Given this list of marker genes ZNF302, C7orf25, ERG28, ZNF814, ZNF732, N4BP3, HNF4G, ZNF268, ZNF384, CTAGE1, KLC4 (NCBI Gene Id 89953), XKR6, ZNF584, MSTO1, ZNF559-ZNF177, ZNF124, BRK1, LIMD2, UBTD2, LARP1B, EBAG9, RPS3, SPEN, AGO1, ZNF559, TMEM178B, GCC1, ZNF440, ZFYVE9, UGT8, LHX1, KCNIP1, PDXK, HDDC3, IKZF2, ZNF544, HOXD13, CAP1, GALNT2, KLHL32, THEM4, BORCS6, UFM1, UBQLN4, SLC37A3, ZFP90, SEMA3A, ZNF781, CR1, L3MBTL1, DPT, TBC1D16, ZNF586, GRIK4, ASPRV1, MLXIP, ADORA3, GLP1R, ZNF257, CLRN1, ZHX2, FAM120C, XKR7, RXRA, FBLN1, L3MBTL4, U2SURP, ATF6B, SEZ6, TOMM34, B9D1, TMEM212, ZNF594, DBNDD2, GOLGA8B, PTBP2, ZNF135, UBQLN2, TSC22D2, ZNF426, ZNF763, ZNF37A, FASTKD1, IBTK, IGF2BP1, TARDBP (NCBI Gene Id 81927), ORC4, LETMD1, CHEK1, RIMKLB, KIF21A, ZNF189, ZNF629, ZNF773, CSNK2B, MED13L, ZNF439, ABHD13, NEXMIF, SMAP2, ATXN1, FAM237A, CEP162, GDI1, ZNF367, here is a description of the gene set: Genes predicted to be targets of miRBase v22 microRNA hsa-miR-1260a, hsa-miR-1260b in miRDB v6.0 with MirTarget v4 prediction scores > 80 (high confidence targets). species: Homo sapiens Human Gene Set: MIR1260A_MIR1260B from publication Chen Y, Wang X (PMID 31504780)